Given this list of marker genes CACNA1D, ZNF280B, PAFAH1B2, BAZ1B, PPP1R7, ITPRID2, MTRF1L, BNIP5, DLG2, IGSF10, EPHA7, PTPRG, TRAK1, ATG14, CBLL1, BICD2, AADAC, PFN2, TBC1D17, TENM3, TBC1D2, ZNRF3, ZNF213, KCNJ13, YPEL4, DAZAP2, NR1D2, LRP8, SETD3, ZNF513, TIGD2, PLBD1, C5AR2, DCUN1D3, GDAP1, DOCK4, SYT1, MAPK6, URI1, NR4A2, CSRNP3, AGO1 (argonaute RISC component 1), PAFAH1B1, PAPOLB, RNF11, TOB1, NPAS2, PTPN4, KIAA1549L, PRICKLE3, FEZF1, DPYSL5, BCL11B, TBC1D3, MCF2L, DLL1, TBC1D3H, FAT2, ZSWIM6, TLN2, CYB561D1, PRAMEF17, ST6GAL2, GABBR2, CLOCK, GGCX, here is a description of the gene set: from publication Chen Y, Wang X (PMID 31504780) species: Homo sapiens Genes predicted to be targets of miRBase v22 microRNA hsa-miR-33b-3p in miRDB v6.0 with MirTarget v4 prediction scores > 80 (high confidence targets). Human Gene Set: MIR33B_3P